The following is a description of a gene set: species: Homo sapiens A zone of apposition between endoplasmic-reticulum and mitochondrial membranes, structured by bridging complexes. These contact sites are thought to facilitate inter-organelle calcium and phospholipid exchange. Human Gene Set: GOCC_MITOCHONDRIA_ASSOCIATED_ENDOPLASMIC_RETICULUM_MEMBRANE_CONTACT_SITE, and this is the list of marker genes: BCL2L10, ACSL4, MBOAT7, BCAP31, AHCYL1, ATG14, ZFYVE1, TOMM20, ATAD3A, VPS13A, SERAC1, RAB38, TMEM41B, ATG5, CANX, TMX1, STX17, TOMM40, PDZD8, RAB32 (NCBI Gene Id 10981), SELENON, CLCC1, EIF2AK3, TMX2, FATE1